The following is a description of a gene set: studied in species Mus musculus Mouse Gene Set: GOBP_REGULATION_OF_POSTSYNAPTIC_DENSITY_PROTEIN_95_CLUSTERING Any process that modulates the frequency, rate or extent of postsynaptic density protein 95 clustering., and this is the list of marker genes: Cdh2, Zmynd8, Dbn1, Slc30a1, Cript